Given this list of marker genes Wnt4, Akr1c18 (aldo-keto reductase family 1, member C18, NCBI Gene Id 105349), Creb1, Gprc6a, Dkkl1, Prkg1, Bglap2, Cmtm2a, Ggcx, Bglap, here is a description of the gene set: Mouse Gene Set: GOBP_REGULATION_OF_TESTOSTERONE_BIOSYNTHETIC_PROCESS species: Mus musculus Any process that modulates the frequency, rate or extent of testosterone biosynthetic process.